Given this list of marker genes DDIT3, SLC3A2, PDIA4 (NCBI Gene Id 9601), CALU, SELENOM, TMEM45A, PPIB, ISG15, NDRG1, HYOU1, SMIM14, MANF, HSPA5, SELENOS, PDIA3, TMED2, DNAJB11, GBP2, HMOX1 (NCBI Gene Id 3162), TRAM1, SNHG12, LMAN1, SDF2L1 (stromal cell derived factor 2 like 1), SSR2, NUCB2, DNAJC1, ZFAS1, CDK2AP2, ADM, OSTC, ARF4, MT2A, HM13, CRELD2, SLC33A1, SPCS2, PDIA6, TMEM258, DNAJB9, XPOT, SEC11C, CALR, SDC2, TXN, TAP1, AARS1, LY6E, EGLN3, HSP90B1, WARS1, here is a description of the gene set: from publication Gavish A, Tyler M, Greenwald AC, Hoefflin R, Simkin D, Tschernichovsky R, Galili Darnell N, Somech E, Barbolin C, Antman T, Kovarsky D, Barrett T, Gonzalez Castro LN, Halder D, Chanoch-Myers R, Laffy J, Mints M, Wider A, Tal R, Spitzer A, Hara T, Raitses-Gurevich M, Stossel C, Golan T, Tirosh A, Suvà ML, Puram SV, Tirosh I (PMID 37258682) Genes upregulated in subsets of cells of a given type within various tumors species: Homo sapiens In this study, an extensive analysis was conducted to define meta-programs (MPs) capturing intra-tumor heterogeneity across a spectrum of tumor types. The approach utilized non-negative matrix factorization (NMF) to analyze each cell type separately within individual tumor samples. This involved the analysis of malignant cells, macrophages, fibroblasts, endothelial cells, epithelial cells, T-cells, and B-cells. NMF was executed with varying parameter values (K=4, 5, 6, 7, 8, 9), thereby generating 39 programs for each cell type per sample. Each NMF program was summarized by the top genes based on NMF coefficients.\nRobust MPs were then delineated for each cell type using a set of stringent criteria, including recurrence within the same tumor, similarity to programs in other tumors, and non-redundancy within a tumor. Subsequently, these robust NMF programs were clustered (per cell type) based on Jaccard similarity, leading to the identification of MPs associated with each cell type.\nTo enhance the quality of the MPs, a refinement steps were undertaken, involving the removal of MPs suspected of reflecting low-quality data (with an overrepresentation of ribosomal proteins or mitochondrial-encoded genes), single-study inclusion, or similarity to miss-annotated cell types. Human Gene Set: GAVISH_3CA_METAPROGRAM_MACROPHAGES_UNFOLDED_PROTEIN_RESPONSE